Given this list of marker genes Mrpl43, Mterf4, Mrps30, Rpl7, Rpl36a, Mrpl33, Mrpl39, Rpsa, Rps25, Rplp1, Rps27a, Rack1, Rpl36-ps12, Ascc2, Rpl17-ps8 (ribosomal protein L17, pseudogene 8), Rpl37a, Rps20, Ddx3x (NCBI Gene Id 236681), Rpl24, Mrpl28, Mrps15, Oas1g, Mrpl38, Mrpl41, Aurkaip1, Mrpl22, Rpl9-ps6, Eif2a, Rpl34-ps1, Eif2d (eukaryotic translation initiation factor 2D), Mrps12, Rps12, Rpl3l, Rpl37rt, Mcts1, Hbs1l, Mrpl36, Mrpl27, Rpl32-ps, Mrpl2, Mtg1, Hspa14, Rpl5, Rps2, Rpl28, Rps26, Rps27rt, Eif2ak4, Rpl3, Rps17, Gm6525, Rpl22l1, Rnf14, Rpl13-ps6, Mrpl51, Rpl21, Mrpl15, Mrpl14, Larp4, Mrps17, Mrpl47, Rbm3, Rpl32, Rps3a1, Metap1, Rplp0, Rps27, Rps5 (ribosomal protein S5), Rpl10-ps3, Mrpl46, Mrpl4, Mrpl10, Rpl6l, Uba52, Oas1f, Rplp2-ps1, Rpl4, Mrpl21, Fxr1, Mrpl35, Rpl22, Mrpl18, Mrpl42, Pelo, Mrps11, Mrps14, Dazl (deleted in azoospermia-like), Rpl26, Rpl14, Rps18, Psma6, Rpl10a, Fubp3, Zfp598, Rpl9-ps1, Mrps2, Mrpl19, Rpl27rt, Rpl29, Rpl9, Rps19, Mrpl17, Rpl34, Rpl13, Ppargc1a, Mrps35, Rps16, Rnf25, Mrps26, Rpl18a, Uba52-ps, Mrps25, Rps10, Dap3, Rpl10, mt-Rnr2, Mrpl55, Nr0b1, Mrpl3, Rps6, Mpv17l2 (MPV17 mitochondrial membrane protein-like 2), Rplp2, Mrpl16, Oas1h, Eef1a1, Usp10, Mrpl20, Mrpl30, Rpl7l1, Rpl7a, Rpl30, Rpl41, Eef2, Fxr2, Rpl27a, Mtg2, Rpl35, Snca, Rpl8, Zcchc17, Rps4x, Rpl13a, Rps27l, Calr, Oas1e, Rps7, Canx, Rps9, D1Pas1, Abcf1, Rpl32l, Mrps9, Rpl36al, Mrpl11, Oas1b, Mrps24, Mrpl40, Dmd, Elavl4, Rps13, Oas1d, Rpl37, Mrpl1, Rps14, Mrps31, Mrpl12, Mrps23, Dhx29, Rps18-ps6, Mrps28, Mrpl9, Rpl23, mt-Rnr1, Rps3, Mrps5, Rpl36, Mrpl37, Mrps33, Gadd45gip1, Rps24, Nsun3, Rps21, Rnf10, Rps15, Rpl17, Oas1a, Mrpl32, Pnpt1, Rps6kl1, Rpl35rt, Gcn1, Mrpl48, Ltn1, Rpl39, Abce1 (NCBI Gene Id 96976), Oas1c, Rplp1rt, Mrpl45, Mrps18c, Fau, Ptcd3, Mrps18b, Rps29, Eif4g1, Mrpl50, Mrps6, Mrpl24, Mrps7 (NCBI Gene Id 50529), Rps23, Apod, Rps11, Mrps27, Rpl27, Etf1, Rpl31, Uba52rt, Rpl38, Mrpl34, Mrpl53 (NCBI Gene Id 68499), Npm1, Jrk, Mrps21, Nck1, Ascc3, Mrpl23, Rpl15, Mrps34, Mt3, Mrpl57 (NCBI Gene Id 67840), Mrpl58, Rpl39l, Mrpl13, Mrps18a, Rpl12, Nemf, Cpeb2, Mrpl44, Rps15a, Nsun4, Chchd1, Mrpl54, Gspt1, Rps8, Rps6-ps4, Rpl18, Mrpl49, Mrps10, Rpl23a, Rpl35a, Mrps16, Rpl10l, Rpl34-ps2, Gm6133, Rps4l, Rpl6, Repin1, Rpl19, Mrpl52, Mrps22, Rps28, Nufip2, Rpl11, here is a description of the gene set: Mouse Gene Set: GOCC_RIBOSOME An intracellular organelle, about 200 A in diameter, consisting of RNA and protein. It is the site of protein biosynthesis resulting from translation of messenger RNA (mRNA). It consists of two subunits, one large and one small, each containing only protein and RNA. Both the ribosome and its subunits are characterized by their sedimentation coefficients, expressed in Svedberg units (symbol: S). Hence, the prokaryotic ribosome (70S) comprises a large (50S) subunit and a small (30S) subunit, while the eukaryotic ribosome (80S) comprises a large (60S) subunit and a small (40S) subunit. Two sites on the ribosomal large subunit are involved in translation, namely the aminoacyl site (A site) and peptidyl site (P site). Ribosomes from prokaryotes, eukaryotes, mitochondria, and chloroplasts have characteristically distinct ribosomal proteins. species: Mus musculus